Given this list of marker genes JUN, MTOR, CD247, IL22, IFNG, STAT1, IL6, RORA, LCK, CD3E, IL2RA, TGFB1, MAPK8, RUNX1, RARA, CD3D, CD3G, STAT6, JAK1, LAT, IL17F, IL23A (NCBI Gene Id 51561), TGFBR1, ZAP70, HSP90AA1, IL17A, PPP3CA, SMAD2, IL4R, IL23R, IL2, RORC, GATA3, TBX21, STAT5A, MAPK14, NFATC1, IL21R, IL27RA, NR1D1, PRKCQ, PER1, HIF1A, IRF4, RXRA, STAT3, CD4, NFKB1, IL1B, PLCG1, IL21, CLOCK, IL4, IFNGR1, BMAL1, SOCS3, HLA-DMA, IL6R, FOS, JAK2, AHR (NCBI Gene Id 196), CRY1, IL27, TYK2, FOXP3, MAPK1, IKBKB, NFKBIA, NFIL3, here is a description of the gene set: Th17 cell differentiation pathway Human Gene Set: WP_TH17_CELL_DIFFERENTIATION_PATHWAY species: Homo sapiens